Given this list of marker genes Apoc2, Lmf1, Apoc3, Lipc, Ces1g, Apoc1, Apoe, Lipa (lysosomal acid lipase A), Apoc2l, Gpihbp1, here is a description of the gene set: Mouse Gene Set: GOBP_TRIGLYCERIDE_RICH_LIPOPROTEIN_PARTICLE_CLEARANCE species: Mus musculus The process in which a triglyceride-rich lipoprotein particle is removed from the blood via receptor-mediated endocytosis and its constituent parts degraded.